Given this list of marker genes LYZ, TIMP2, CYP1B1 (NCBI Gene Id 1545), GATA6, ITGB5 (NCBI Gene Id 3693), CCL18, GAS6, TBC1D8B, ITGB2, SPARC, PLPP3, CCL2, C3AR1, TYROBP, S100A4, FTH1 (NCBI Gene Id 92182), DAB2, ZNF347 (zinc finger protein 347), FPR1, NXPH3, LMO2 (NCBI Gene Id 8051), CCR5, IL1R1, VMP1, DLC1, DES (desmin), FCER1G, FCGR2A, MYLK (NCBI Gene Id 50483), BBS2, TIMP3, VCAM1, GBP2, GNLY, CSF1R, MMP2, HBA2, CCN1, CTSB, CXCL9, DAPK1, CCL5, FCGR1A, CD63, CTSL (cathepsin L), IL2RB, SRRM2, CXCR6, TNFSF13, CCR2, THBS1, HLA-DOA, CCR1, CCL14, MMP9, CD151, LAG3, PCDH9, KCTD12, FADS1, CYBB, FN1, GZMK, IER3, CD14, CCL21, IFITM2, LGMN, FTL, IFI30, A2M, CPM, FAP, MAPK12, CXCL12, CYP27A1, PDGFRB, TNFAIP6, IL32, SLC1A1, CCL11, VWF, IFITM1, CDH13 (NCBI Gene Id 1012), CCND2, DCTN3, APOL3 (NCBI Gene Id 80833), MMP1, GPX1, AIF1, MGLL, EARS2, GBP1, CEBPD, GJB1, PDGFRA, VIM, IFITM3, TIMP1, here is a description of the gene set: species: Homo sapiens Human Gene Set: MODULE_79 Genes in the cancer module 79.